The following is a description of a gene set: studied in species Mus musculus Binding to a monocarboxylic acid, any organic acid containing one carboxyl (COOH) group or anion (COO-). Mouse Gene Set: GOMF_MONOCARBOXYLIC_ACID_BINDING, and this is the list of marker genes: Akr1c13, Cyp4f14, Acox3, Fabp3, Stx3, Cyp4f15, Vdr, Rbp7 (retinol binding protein 7, cellular), Akr1c20, Insr, Lcn12, Arhgdia, Akr1c19, Hnf4a, Acoxl, Acox1, Pmp2, Sh3glb1, Alb, Rida, Cyp26b1, Cyp4a14, Nod2, Ugt1a1, Scp2, Prr7, Ugt1a7c, Ptgds, Rara, Ugt1a10, Nme2, Alox5ap, Cyp2w1, Dbt, Gsta13, Crabp1, Akr1c6, Akr1c18, Adh5, Psap, Gstp-ps, Gsta2, Ugt1a2, Pitpna, Pygl, Akr1c14, Gsta5, Fabp5, Snca, Lrat, Fabp1, Nr2f2 (NCBI Gene Id 67192), Akr1cl, Gstp2, Tmem175, Id3, Ugt1a8, Pla2g1b, Pcx, Akr1c12, Cd36, Dgat1, Gsta1, Fabp9, Fabp4, Fabp6, Acacb, Rxra, Napepld, Fabp2, Gstm7, Nr1h4, Ffar1, Ucp1, Gstp1, Cyp26c1, Pparg, Fabp12, Igf2r, Fabp7, Crabp2, Rbp1, Cyp26a1, Cyp4f40, Rbp2, Acaca, Serpina5, Akr1c21, Apoc1, Hlcs, Acox2, Gpr31b, Ffar4, Ppard, Gstp3, Ugt1a9